The following is a description of a gene set: species: Mus musculus Any process that modulates the frequency, rate or extent of the directed movement of sodium ions (Na+) into, out of or within a cell, or between cells, by means of some agent such as a transporter or pore. Mouse Gene Set: GOBP_REGULATION_OF_SODIUM_ION_TRANSPORT, and this is the list of marker genes: Nedd4, Scn1b, Serpine2, Cnksr3, Nherf1, Drd4, Scn4b, Scn3b, Atp2b4, Ank3, Gpd1l, Fxyd6, Tgfb1, Ywhah, P2rx7, Wnk1 (NCBI Gene Id 406236), P2rx4, Neto1 (neuropilin (NRP) and tolloid (TLL)-like 1), Nkain2, Fxyd2, Cxcl1, Atp1b3, Wnk2, Nkain3, Slc9a3, Nkain1, Cntn1, Per1, Cav3, Wnk3, Atp1b1, Fxyd5, Fxyd1, Rangrf, Slmap, Nos3, Camk2d, Slc8a1, Ahcyl1, Fgf12, Dmd, Sgk1, Adrb2, Bpifa5, Arf1, Chp1 (NCBI Gene Id 80510), Scn5a, Fxyd7, Prss8, Tmem168, Nos1, Pcsk9, Fxyd4, Atp1b2, Scn2b, Kcnq1, Ptpn3, Drd2, Nkain4, Atp1a1, Mllt6, Nedd4l, Ikbkb, Fgf14, Dmpk, Osr1, Scnn1b (NCBI Gene Id 20277), Sik1, Snta1, Nkx2-5, Sptbn4, Bpifa1, Agrn, Akt1, Stk39, Fgf13, Slc9a1, Plcb1, Grp (gastrin releasing peptide), Commd1, Fxyd3, Tescl, Akt2, Akt3, Wnk4, Tesc, Gnas (GNAS complex locus)